Given this list of marker genes H2-Q10, H2-M3, B2m, H2-M10.1, H2-M10.6, H2-Q7, H2-M10.2, H2-M9, H2-M2, here is a description of the gene set: part of: Antigen processing-Cross presentation studied in species Mus musculus electronically inferred by orthology from the curated human pathway This event has been computationally inferred from an event that has been demonstrated in another species.<p>The inference is based on the homology mapping from PANTHER. Briefly, reactions for which all involved PhysicalEntities (in input, output and catalyst) have a mapped orthologue/paralogue (for complexes at least 75% of components must have a mapping) are inferred to the other species. Reactome Pathway: Endosomal/Vacuolar pathway